The following is a description of a gene set: Mouse Gene Set: CUI_CDC2_IL1A_RESPONSE_DN Cytokines mediate cell-cell communication in the immune system and represent important therapeutic targets. A myriad of studies have highlighted their central role in immune function, yet we lack a global view of the cellular responses of each immune cell type to each cytokine. To address this gap, the authors created the Immune Dictionary, a compendium of single-cell transcriptomic profiles of more than 17 immune cell types in response to each of 86 cytokines (>1,400 cytokine-cell type combinations) in mouse lymph nodes in vivo. A cytokine-centric view of the dictionary revealed that most cytokines induce highly cell-type-specific responses. For example, the inflammatory cytokine interleukin-1β induces distinct gene programmes in almost every cell type. A cell-type-centric view of the dictionary identified more than 66 cytokine-driven cellular polarization states across immune cell types, including previously uncharacterized states such as an interleukin-18-induced polyfunctional natural killer cell state. from publication Cui A, Huang T, Li S, Ma A, Pérez JL, Sander C, Keskin DB, Wu CJ, Fraenkel E, Hacohen N (PMID 38057668) species: Mus musculus Genes negatively differentially expressed in cell type: cDC2 (conventional dendritic cell type 2) upon treatment with cytokine: IL-1α in mouse lymph nodes in vivo., and this is the list of marker genes: Slc43a2 (solute carrier family 43, member 2), Bckdha, Ly86, Inpp5d, Map4k2, Lcorl, Ccl6, Dbi, Rubcnl, Ckb, Ptk2, H2-Eb1, Hlcs, Arid1a, R3hdm4, Zmiz2, Mdp1, Scarb1, Eid1, Fos, Cd37, Lrrk2, Arl4c, Cdk14, Cebpa, Pld4, L1cam, Myo5a, Hmgb1 (NCBI Gene Id 15289), Prcp, Hps3, Lrrc25, Clic1, Map3k5, Tmem219, Plekha2, Ptma, Stard3nl, Nfix, Snx21, Gpx4, Asnsd1, Phf14, Rgs3, Dpm3, Septin3, Plekhm3, Nsa2, Eeig2, Slc66a2, Fyb1, Btg2, Ptpra, Plcg2, Akap10, Pigp, BC028528, Srd5a3, Lman2l, Zbtb20, Tmem176b, Coro1a, Eif4b, Ptgs2, Ccl9, Ssbp3, Evl, Slc15a4, Dna2, Sdc3, Idh2, Entpd1, Rnpep, Ttc7 (NCBI Gene Id 75468), Cd2ap, Plcb2, Pitpnc1, Ndufa6, Plac8, Ifngr1, Ccdc88c, Abl1, Elmo2, Hexa, Rasgrp4 (RAS guanyl releasing protein 4), Iqgap2, Macf1, Slc12a6, Pals2, Itgal, Septin9, Cbfa2t3, Ptprc, Oxct1, Erp29, Txnip, Ctsc, Cyp27a1, Sap30, Tln1 (NCBI Gene Id 21894), Rraga, Arrb1, Tep1, Pnisr, Creg1, Lbh, Mink1, Gpr141, Fosb, Clec4a3 (NCBI Gene Id 73149), Hsd17b11, Dctpp1, Slc2a3, Chka, Klhl24, Gsn, Susd3, Septin6 (NCBI Gene Id 80615), Smchd1, Tgfb1 (NCBI Gene Id 21803), Camkk2, Slc35c2, Calhm2, Jarid2, Anxa1, Glipr1, Mtpn, Il10rb, Unc93b1, Bri3, Cd300lg, Ppp3ca, Plp2, Ramp1, Nedd4, Tpi1, Hk2 (NCBI Gene Id 15277), Fuca1, Cd68, Cmtm7, Ppt2, Hmgcl, Pold4, Zmiz1, Ank, Plbd1, Kmt2e, Csf1r, Gusb, Ptms, Dock2, Snx10, Tifab, Ccr2, Atf7ip (NCBI Gene Id 76012), Ptpn18 (NCBI Gene Id 19253), Zfp385a, Atp8a1, Lpin2 (lipin 2), Bnip3l, Borcs6 (BLOC-1 related complex subunit 6), Calhm6, Dkc1, Arhgdib, Nfatc2, Nup210, Plekhf2, Ptp4a3, Slamf8, Bcap31, Anxa6, Marveld1, Cox7a2l, Herc1, Hspa1a, H2-Oa, Kdm7a, Taok3, Gpsm3, Nfkbid, Cnp, Scp2, Grn, Bscl2 (BSCL2 lipid droplet biogenesis associated, seipin), Naga, Il6st, Ftl1, Cd52, Smarca2, Psap, St8sia6, Tmem59, Arhgap17, Rgs10, Abcd1 (ATP-binding cassette, sub-family D member 1), Celf4, Rnase6, Crip1, Lamtor4, Plekho2, Chil5, Itm2b, Fcor, Hck, Nap1l1, Tbl1xr1, Sgpp1, Tmem50a, Ech1 (NCBI Gene Id 51798), H2-K1, Pak1, Evi2a, Hint1, Ssh2, Nr4a1, Sptssa, Ighm, Slc31a2, Higd2a, Selenop, Adgre1, Sp100, Sox4, Ctsb, Shtn1, Abi3, Tnfrsf21, Dgkd (diacylglycerol kinase, delta), Taldo1, Ctsh, Nceh1, St8sia1, Plxnb2, Mia2, Lag3, Vdac2, Itpr1, Nr4a2, B4galt6, Ffar4, Cyba, Dpy19l1 (NCBI Gene Id 68435), Aph1c, Slc48a1, H2-DMa, Rnf166, Ppp1ca, Rasgrp2, Pot1b, Nsmaf, Tubb5, H2ac25, Ptafr, Ttc3, Tmem50b, Pcbd2, Lrwd1, Colgalt1, Mpc2, Epcam, Tent5a, Clec4b1, Irf8, Klf4, Stom, Lat2, Fxyd5, Carmil1, Ppa2, Rgs18 (NCBI Gene Id 64214), Man2b1, Lipa, Cyfip2, Hexb, H2-D1, Arsb, Zfp36l2, Fbrsl1 (fibrosin-like 1), Ccnd1, Cd300a, Npc2, Mxd4, Dock10, Stard9, Pip4k2a, Rasa4, Nfe2l2, Bmyc, Daglb, Cd300ld, Fcer1g, Arl11, Lpin1, Atp5f1c, Tceal9, H2az1, Lmo1 (LIM domain only 1), Lyz2, Eef2, Ndufv3, Mbnl1, Arhgap15, Npc1, Rxra, Klf2 (NCBI Gene Id 16598), Trappc5, Plekho1, Plxdc1 (NCBI Gene Id 72324), Tor3a, Hpse, Slc6a6, Tnni2, Tm6sf1 (transmembrane 6 superfamily member 1), Clec4a1, Gdi2, Jun, Pik3cd, Gas2l3, Gngt2, Dek, Arhgap9, Slc20a1, Slc46a3, Gcnt1, Itgb7, Ptpro, Gns, Stard5, Adcy7, Pltp, Timp2, Zfp710, Abca1, Tmed10, Ndufa13, Anp32a, Smim14, Rfc1, Asap1, Lsp1, Flt3, Grap, Tnfaip8l2, Cotl1, Clec4a2 (C-type lectin domain family 4, member a2), Pycard, Ndufb10, Vamp5 (vesicle-associated membrane protein 5), Tut4, Limd2 (NCBI Gene Id 67803), Laptm5, Plekhg3, Arhgap25, Bcl11a, Abcg1, Mrpl33, Pdlim2, Slc29a3, Celf2, Rp2, Mef2c, Dnajc15 (NCBI Gene Id 66148), Cdc42se2, Bin1, Mical1, Dut, Ctss, Cd47, Uqcc2, Clec12a, Eif3f, Sirpa, Gltp, Serf2, Emp3, Tecr, Ptprcap, E2f2, Ncf2, Ppfia4, Fes (feline sarcoma oncogene), Spns3, Hltf, Zfp652, 9930111J21Rik2, Gmfg, Cadm3, Psme2b, Irag2, Ptk2b, Snx18, Prr5l, Reep5, Emb, Stk38, Plxnd1, Ccrl2, Ndufc2, Mcemp1, Ccpg1, Wdfy2 (WD repeat and FYVE domain containing 2), Rgl1, Ier5, Cd4, Atp5if1, Exosc5, Adss1 (adenylosuccinate synthase 1), Igsf8, Abca9, Parp8, Tifa, Vav3, Idh1, Zfp467, Myo9b, Coq10b, Rhob, Smc6, Camk1d, Pglyrp1, Epsti1 (epithelial stromal interaction 1), Tet3, Epb41l4aos, Rgs2, Fkbp4, Fgd2, Rcsd1 (NCBI Gene Id 77931), Naip2, Selenoh, Gm2a, Akr7a5, Eif3h, Il13ra1, Siva1, Eif4e3, H2-Ab1, Spn, Arhgef18, H2-T23, Eif3e, Ncor2, Rassf4, H2-DMb1, Sod1, Nfam1, Klrd1, Trf, Pea15a, Ptprj, Rfx7, Otulinl, Sema4d, Add3, Sms, Nav1, Tyrobp, Alox5ap, Ccr9, Sdf2l1, Asah1, Cd7, Wls, Clec2i, Lyl1, Ctsa, Lmo4 (LIM domain only 4), Vsir, Sulf2, Amz1, Neat1, Tsc22d4, Marchf1, Pstpip1, Uggt1, Kxd1 (NCBI Gene Id 97450), Rere, Bri3bp, Mapk14, Nek7, Lage3 (L antigen family, member 3), Osgep, Gpi1 (glucose-6-phosphate isomerase 1), Jup, Rnaseh2c, Zeb2, Cx3cr1, Mrpl28, Slc25a5, St13, Mrpl42, Dnajb14, Mpeg1, Tpd52, Aif1, Rbfa, Myo1f, Rab32 (RAB32, member RAS oncogene family), Rnf130, Rsrp1, Il16, Ctsd, Cd81, Lgals1, Arhgef1, Slc38a1, Cd180, Ptp4a2, Nadk, H2ac24, Lgals3 (lectin, galactose binding, soluble 3), Dhrs7, Themis2, Bin2, Sec11c, Nr3c1, Ubac2, Lst1, Apbb1ip, Tmsb10, Nes, Pnpla7, Dnajc7, Ptpre, Bst2, Dpysl2, Mcub, Ubc, Atf3, Cybb, Ms4a6c, Igsf6, Ypel3, Ear2, Ppt1, Fam111a, Pgap1, Sowahc, Trps1, Haus8, Lyz1, Skint3, Samd9l, Abhd17a, Mgat1, Tmed3, Junb, Macroh2a1, Lyst, Anxa5, Cd200r1, Arhgef6, Apobec1, Ehd4, Cox20, Chd9, Akr1b1, Mfsd6, Plin2, Egr1, Ucp2, Sh3bgrl3, Itgb2, Irgm1, Dock11, Ptpn22, Cox6b2, Tmem86a, H2-Aa, Slc12a9, Sh3kbp1, Smim5, Dock4, Abhd12, Itgax, Foxp1, Uhrf2, Hspa1b, Ptpn6, Arpc5l, Shisa5, Tkt, Pid1, Ifitm6, Aldh2, Hmgb2, Tnrc18, Scarb2, Map3k4, Ly6e (NCBI Gene Id 17069), Tmem238, Arid5b, Klf10, Hes6, Dipk1a, Sat1, Hpgd, Gng2, Stap1, Adgre4, Dnase2a, Gnai2, L3mbtl3, Gpx1, Arhgap45, Cib1, Smim29, Arap1, Cd300c2, Il17ra